The following is a description of a gene set: studied in species Mus musculus A multicellular organismal process involved in the periodic casting off and regeneration of an outer covering of cuticle, feathers, hair, horns, skin. Mouse Gene Set: GOBP_MOLTING_CYCLE_PROCESS, and this is the list of marker genes: Pdgfa, Zdhhc21, Ngfr (NCBI Gene Id 18053), Gal, Ptgs2, Lgr4, Lrig1, Gorab, Dkk1, Rela, Trp63, Wnt10a, Barx2, Mysm1, Tnfrsf19, Gsdma3, Rbpj, Apcdd1 (adenomatosis polyposis coli down-regulated 1), Apc, Nsun2, Ctsl, Sostdc1, Tgfb2, Wnt5a, Gli2, Fermt1, Alx4, Snai1, Lncpint, Fgf7, Dicer1, Ppard, Myo5a, Trpc4ap, Krtap21-1, Inhba, Hdac2, Foxe1, Cdh3, Igfbp5, Egfr, Nom1, Psen1, Numa1 (nuclear mitotic apparatus protein 1), Trps1, Dbi, Ldb1, Nsdhl, Dkk4, Tfap2c, Celsr1, Lamc1, Mfsd12, Fst (NCBI Gene Id 99160), Naglu, Tnf, Sox21, Fzd3, Tmem79, Lama5, Norad, Zmpste24, Dlx3 (NCBI Gene Id 13393), Krt71, Krt17, Edar, Foxq1, Mreg, Sox18, Krt25, Dsc1, Acvr1b, Lgr5, Col6a1, Hpse, Ldb2, Smo, Akt1, Runx1, Runx3, Smad4, Ercc2, Dnase1l2, Tspear, Psen2, Intu (NCBI Gene Id 77903), Pias4, Cd109, Foxn1, Nf1, Sos1, Trpv1, Hoxc13, Bcl2, Fgfr2, Krt28, Shh, Krt27, Krtap6-2, Sox9, Pum2, Notch1, Fuz, Wnt10b, Hdac1 (NCBI Gene Id 630524), Pkp3, Foxi3, Fgf10, Vangl2, Pla2g10, Atp7a, Msx2, Edaradd, Farp2, Lhx2, Sav1, Ctnnb1, Lrp4, Tradd, Prss8 (NCBI Gene Id 97375), Eda, Fzd6, Dsg4, Gnas, Ext1 (exostosin glycosyltransferase 1)